The following is a description of a gene set: Marker genes curated from the annotated cluster as represented in the Descartes Human Gene Expression During Development database. Human Gene Set: DESCARTES_FETAL_ADRENAL_MYELOID_CELLS studied in species Homo sapiens from publication Cao J, O'Day DR, Pliner HA, Kingsley PD, Deng M, Daza RM, Zager MA, Aldinger KA, Blecher-Gonen R, Zhang F, Spielmann M, Palis J, Doherty D, Steemers FJ, Glass IA, Trapnell C, Shendure J (PMID 33184181) The gene expression program underlying the specification of human cell types is of fundamental interest. The study authors generated human cell atlases of gene expression and chromatin accessibility in fetal tissues. For gene expression, the study authors applied three-level combinatorial indexing to >110 samples representing 15 organs, ultimately profiling ~4 million single cells. The study authors leveraged the literature and other atlases to identify and annotate hundreds of cell types and subtypes, both within and across tissues. Our analyses focused on organ-specific specializations of broadly distributed cell types (such as blood, endothelial, and epithelial), sites of fetal erythropoiesis (which notably included the adrenal gland), and integration with mouse developmental atlases (such as conserved specification of blood cells). These data represent a rich resource for the exploration of in vivo human gene expression in diverse tissues and cell types., and this is the list of marker genes: PTAFR, MS4A4A (NCBI Gene Id 95933), SPIC, GPR34, GPBAR1, CCDC200, RGS1, HMOX1 (NCBI Gene Id 3162), SLAMF8, KCNE1, SIRPB1, LILRA5 (leukocyte immunoglobulin like receptor A5), MTCO1P11, LILRB3, SLC11A1 (solute carrier family 11 member 1), SIGLEC10, CD80, LINC01182, MERTK, FCN1, CALHM6, NLRC4, CCR1, ADGRE1, HK3, TRPM2, HRH1, CD5L, TLR5, LINC01480, SMIM35, IGSF6, RYR1, RIPK3, FCGR1BP, C1QC, SIGLEC8, SECTM1, FGD2, OSCAR (osteoclast associated Ig-like receptor), TMEM273, TLR1, EFCAB15P, PELATON, C5AR1 (complement C5a receptor 1), MSR1, PDYN-AS1, LILRA1, ENSG00000231873, MX2, SPI1 (Spi-1 proto-oncogene), P2RY13, LINC03070, IER3, HLA-DPA1, LRRC25, ENSG00000253557, CLEC10A, LILRA6, MNDA, RNASE6, TNFRSF11A, SIRPB2, TIMD4, ENSG00000227531, TLR6, KCNK13, MS4A7, MS4A4E, CD300C, HLA-DMA, ENSG00000254288, MILR1, SLC1A3, MS4A6A, LILRB1, SCIMP, LYZ, SLC7A7, RNF135, HLA-DMB, NFAM1, TYMP, FPR1, HLA-DRA, SIGLEC14, LILRB4 (leukocyte immunoglobulin like receptor B4), PRAM1, CCDC26, TRIM50, CXCL8, TMEM150B, HELZ-AS1, KCNG2, SIGLEC12, NLRP3 (NCBI Gene Id 9558), VSIG4, ADAM28, P2RY12, ADAP2, TMEM106A, CASP5, RAB39A, CD163, C3AR1, PDCD1LG2, SLC7A8, CSF1R, IL1RN, ITGAX, NAIPP3, FOLR2, HCK, CD86, GGTA1 (NCBI Gene Id 728926), SLCO2B1, MEFV, SPP1, CD68, NOD2, PILRA, ZMYND15, NAIP, LINC01684, TGFA, FAM20A, CST3 (NCBI Gene Id 1471), CLEC4F, CD33, RUFY4, RN7SL297P, MRC1, TLR2, UNC93B1, CMKLR1, RN7SL138P, MS4A14, SIGLEC1, MARCO, IL10, CLEC7A, CD14, MSLN, HLA-DPB1, NCF2, CYTH4, FGL1, ASCL2, HLA-DRB9, C1QB, SLC37A2, FCGR1A, CD300LF, CD4, LINC00996, PLAUR, LINC01645, LINC01094, CFD, LGMN (legumain), CXCL10, TMIGD3, KCNJ5-AS1, AGR2, CPVL, RNASET2, FLT3, PLA2G7, LILRA2, CYBB, C1QA, LILRB2, CTSZ, SIGLEC16, TREM2, HLA-DOA, MPEG1, SLC39A13-AS1, HLA-DRB1, CD209, SIGLEC5, LILRB5 (leukocyte immunoglobulin like receptor B5), HLA-DQB1, LACC1, ADGRE2, HLA-DQA1, IFNGR1, FPR3, CD163L1